Given this list of marker genes MIR329-1, PGF, ATP2B4, KDR, VCAM1, TSPAN32, PRKD1, DLL4, ROBO1, PIK3CA, MAPKAPK2, FBXW7-AS1, ADAMTS3, VEGFD (NCBI Gene Id 2277), PIK3CD, MIR20A, VEGFA, CCBE1, TNXB, ERN1, JCAD, DCN, FLT1, MIR196A1, MAP2K3, SPHK1, MIR424, PIK3CB, MT1G, PROX1, HRG, ADAMTS12, NR4A1, SMOC2, IL12B (interleukin 12B), XBP1, ITGB1, NUS1, ANXA1, MIR21, VTN, DAB2IP, FOXC1, CADM4, EGR3, ANGPT1, NR2F2, GREM1 (NCBI Gene Id 7947), PDGFRA, VEGFC, MIR26A1, AKT1, MIR27A, MIR23A, SEMA6A, MYO1C, GAS1, MIR199A1, NRP2, PRKD2, ITGA5, FLT3, IL12A, ADGRA2, MAPK14, MIR16-1, HSPB1, MIR342, MIR27B, EMILIN1, RELA, SPRY2, FLT4, ADGRG1, RAMP2, NOTCH1, DLL1, PTP4A3, CD63, NRP1, ITGB1BP1, GAB1, ITGB3, PDGFRB, VEGFB, here is a description of the gene set: Human Gene Set: GOBP_CELLULAR_RESPONSE_TO_VASCULAR_ENDOTHELIAL_GROWTH_FACTOR_STIMULUS species: Homo sapiens Any process that results in a change in state or activity of a cell (in terms of movement, secretion, enzyme production, gene expression, etc.) as a result of a vascular endothelial growth factor stimulus.